Given this list of marker genes SLC15A4, IKBKG, IRF5, CHUK, TASL, IKBKB, here is a description of the gene set: studied in species Homo sapiens part of: Toll Like Receptor 7/8 (TLR7/8) Cascade; Toll Like Receptor 9 (TLR9) Cascade <p>Solute carrier family 15, member 4 (SLC15A4, also known as PHT1) is a proton-coupled L-histidine/oligopeptide transporter. In addition to its function as a transporter, SLC15A4 regulates TLR7-9 signaling pathways in late endosomes/lysosomes (Heinz LX. et al., 2020; Kobayashi T et al., 2021). SLC15A4 acts as a signaling scaffold, recruiting the protein TLR adaptor interacting with SLC15A4 on the lysosome (TASL) to the cytosolic surface of endolysosomes (Heinz LX. et al., 2020; Custodio TF et al., 2023; Chen X et al., 2023). Upon activation of endosomal TLR signaling, TASL undergoes phosphorylation and recruits IRF5 to its pLxIS motif (Heinz LX. et al., 2020). The SLC15A4:TASL complex facilitates IRF5 phosphorylation by IKBKB (IKKβ) and subsequent IRF5 homodimerization downstream of TLR7-TLR9 (Heinz LX. et al., 2020; Zhang H et al., 2023; Chen X et al., 2023; Boeszoermeny A et al., 2023). Once activated, IRF5 translocates to the nucleus to induce the transcription of genes encoding type I interferons (IFNs) and pro-inflammatory cytokines. Hyperactivation of the SLC15A4:TASL:IRF5 pathway, often caused by the detection of endogenous nucleic acids, leads to increased production of type I IFNs and is associated with pathogenesis of inflammatory diseases such as systemic lupus erythematosus (SLE) (Odhams CA et al., 2019; Heinz LX. et al., 2020; Kobayashi T et al., 2021).<br> Reactome Pathway: SLC15A4:TASL-dependent IRF5 activation